Given this list of marker genes TMEM176A, APLP1, RASA4, ARX, PROC, COL12A1 (NCBI Gene Id 1304), GABRB3, KIF1A, CHGB, SPTSSB, MAPK8IP2, RGS17, SEZ6L2, MATN2 (NCBI Gene Id 4147), ELAPOR1, ANK2, C21orf58, STMN2, RIMS2, ARFGEF3, SCG3 (NCBI Gene Id 29106), HES6, RIC3, NEURL1, PCSK1, DNAJC12, CAMK2B, RUNDC3A, PLPPR2, PGAM2, CFC1B, RAB3B, GHRL, SLC12A5, KCNH6, GPC6, EYA4, FFAR4 (free fatty acid receptor 4), CDH10 (NCBI Gene Id 1008), CXXC4 (NCBI Gene Id 80319), NEUROD1, MAB21L4, TRNP1, MAPK8IP1, DPP10, SV2B, CASZ1, VWA5B2, CHGA, DIRAS2, TNFRSF21, CACNA2D1, HEPACAM2, SEMA3A (NCBI Gene Id 63232), TTR, CFC1, RASA4B, AMPH, NKX2-2, NSG2 (NCBI Gene Id 51617), RTN1, TMEM176B, RUNX1T1, RAB26, CELF3, TAGLN3, LINC00261, INHBA, CALY, CA8, CADPS, GNAO1 (NCBI Gene Id 2775), ABCC8, DST, A1CF, KCNJ6, CD200, STMN3, CNIH2, CLIP3, FSTL5, HIVEP3, NRXN1, ANKH, SCG2, CDHR3, MS4A8, RIMBP2, PDE8B, PNMA2, PEX5L, VTN, NAAA, BACE1, PCSK2, INSM1, PPP1R1A, MAP1B, JAKMIP2, RGS4, MAPRE3, SYT5, ARHGEF26, SYP, STX1A, LYSMD2, SNAP25, GNG2, CACNB2, TMEM51, CACNG4, SSTR2, SYT11, CNNM1, MMRN1, ISL1, GPRIN3, PSD, HLA-B, NPDC1, MIR7-3HG, BTBD17, LY6H, CEP126, TSPAN7, ATP2A3, THSD4, QPCT, RFX6, VSTM2L, KLHL32, CNTNAP2, NLRP1, RNF128, A4GALT (NCBI Gene Id 53947), GPBAR1, GPX3, SNCA, PAPSS2, KCNH2, SRRM4, TCEAL2, PROX1, RAP1GAP2, IL1RAP (interleukin 1 receptor accessory protein), SYT4, RAPGEF4, PTPRN, CLDN5, ST8SIA3, CPLX2, UNC80, MAFB, ACSL1, SCGN, here is a description of the gene set: from publication He P, Lim K, Sun D, Pett JP, Jeng Q, Polanski K, Dong Z, Bolt L, Richardson L, Mamanova L, Dabrowska M, Wilbrey-Clark A, Madissoon E, Tuong ZK, Dann E, Suo C, Goh I, Yoshida M, Nikolić MZ, Janes SM, He X, Barker RA, Teichmann SA, Marioni JC, Meyer KB, Rawlins EL (PMID 36493756) Human Gene Set: HE_LIM_SUN_FETAL_LUNG_C1_GHRL_POS_NEUROENDOCRINE_CELL GHRL+ neuroendocrine species: Homo sapiens